The following is a description of a gene set: Human Gene Set: HP_ABNORMAL_MYELINATION Any anomaly in the process by which myelin sheaths are formed and maintained around neurons. species: Homo sapiens Abnormal myelination, and this is the list of marker genes: RNASEH1, NDUFS6, NDRG1, NRROS, NDUFS4, EIF2B1, MPZ, TYMP, BCS1L, GLUL, DHFR, GNAO1, HMBS, TAF2, LAMB1, PIGY, PGAP3, ALG9, ARHGEF10, ITPA, FANCB, PIGA, INTU, NAE1, ZFYVE26, NDUFS3, NR2F1, IDUA, CRELD1, ACTL6B, GRIN1, GRIN2D, KIF1B, TAF13, IER3IP1, LEMD2, PGAP1, GEMIN4, PIGS, COG3, GBF1, PRUNE1, SLC12A5, AP3B2, CHKA, FOXP1, MT-TH, CLTCL1, IREB2, VRK1, ESAM, SMPD4, SLC35B2, KARS1, MT-CO3, SHANK3, NDUFV2, GABBR2, IFIH1, SNIP1, PRF1, MT-ND6, TMEM126B, NGF, TIMM22, ZNF335, GDAP1, SLC2A1, TMEM147, KCNT1, SDHB, DYRK1A, GFAP, LIAS, TWNK, CYFIP2, TYROBP, NDUFS1, WWOX, COG7, SP110, MT-ATP6, ALS2, NIPBL, HS2ST1, BOLA3, MED17, POLR3B, POLR1C, FCSK, RMND1, IBA57, UBA5, GRM7, YARS1, BMP4, FOXG1, MME, DALRD3, NCDN, PTEN, TAOK1, TFG, MTTP, ARID1B, ATP6V1A, FIG4, GTF2H5, PEX10, COG5, DHX30, DARS1, CHAMP1, EXOC2, TPR, RAB3GAP2, TXN2, EPRS1, NDUFAF1, TRAK1, KCNB1, RAB7A, INTS11, LITAF, NDUFS7, BAG3, AIFM1, AHDC1, GNB1, PI4KA, MMACHC, CLCN3, CLDN11, NDUFV1, GAA, ARX, PPP2CA, CSF1R, PIGO, TRMT5, GRIN2A, KMT2E, TREM2, DDOST, MAT1A, UFC1, ATXN2, COA7, AHCY, MT-CO2, WDR26 (NCBI Gene Id 80232), YME1L1, ERCC2, INSR, PIGU, DHH, NUP188, COA8, FUS, PNPT1, ADAR, FLVCR1, ARF1, PRPS1, TIMMDC1, NDUFB11, TGFB1, RNF168 (NCBI Gene Id 165918), TMEM63A, TRAPPC11, RFX7, CNTNAP1, MDH2, ZNHIT3, ALG14, ASPA, RNU7-1, MT-TL1, ZFR, PIGN, AFG3L2, KCNA1, PEX13 (NCBI Gene Id 5194), ATP11A, HYCC1, MT-TF, YY1, PPP1R15B, MT-ND1, DCAF8, CTNNB1, NDUFS2, ALDH6A1, ATP6AP2, KCNC2, DHX16, DMXL2, HNRNPU, MRPS22, CNOT3, POLR2A, TMEM240, SLC1A2 (solute carrier family 1 member 2), RETREG1, MANBA, SYNGAP1, POGZ, FOXRED1, HNRNPC, RNF113A, PRMT7, KCNJ10, ERCC4, CYB5A, ALG12, C2orf69, ELOVL1, PLCB1, MPLKIP, FBXL4, HEXB (hexosaminidase subunit beta), PSAT1, HARS1, EARS2, CTC1, POLR3A, PAK1, ATP9A, ADCY6, LIG3, ISCA2, MORC2, NUS1, ACY1 (NCBI Gene Id 95), RAB3GAP1, NDUFB10, TKFC, PPP3CA, DNM2, KCNH5, PEX7, D2HGDH, BCAS3, GPT2, SLC25A1, L2HGDH, EZH2, TUFM, RNASEH2B, FBP2, SAMHD1, GTPBP3, JPH1 (junctophilin 1), PGM3, GABRA2, VPS33A, CACNA1A, DARS2, FRMD5, SMG9, ALG8, PHACTR1, TMTC3, CTSK, PRX, STXBP1, PURA, CELF2, NUP133, BCAP31, MT-TS2, MLYCD, UBE3A, POLR1A, NDUFAF3, SZT2, SPTLC1, MT-TV, QARS1, C18orf32, SNORD118, NARS2, PIBF1, FGF12, OSTM1, MOCS1, LIPT2, RRM2B, UGDH, ALG11, SLC35A2, MARS1, PEX16, CLPB, CLTC, MPV17, RNF220, TNR, RARS1, RNU4-2, COX6B1, AIMP2, SLC1A4, KLC2, GJC2, SELENOI, CASK, SETD1A, GRIK2, SCN9A, FLRT1 (fibronectin leucine rich transmembrane protein 1), LSM11, SPTBN4, MTRFR, NTRK1, MT-TK, AP3D1, SMPD1, YWHAG, CTDP1, DDX6, ZFX, RAB11B, GATAD2B, NDUFB9, GNB2, PYCR2, SUMF1, EXOSC1, ARSA, ZNF526, PKDCC (protein kinase domain containing, cytoplasmic), SLC32A1, PIGQ, FLCN, C2CD3, NOTCH2NLC, POLG, LMX1B (LIM homeobox transcription factor 1 beta), ALG13, SLC13A5, NEFL, SPTAN1, ADAMTSL1 (NCBI Gene Id 92949), PGAP2, ERCC1, PLAAT3, UBTF, PIGP, DNM1, GCDH, MAPK8IP3, KIF5A, UPB1, TRIM8, GALC, PEX19, SLC30A10 (solute carrier family 30 member 10), ASNS, NDUFA6, ACER3, NGLY1, PRKDC, MTHFS, RAI1, HK1, FAR1, ERCC6 (ERCC excision repair 6, chromatin remodeling factor), EIF2AK2, SLC12A6, AARS1, MT-ND5, PMM2, HSPB8, ABCA1, SIN3A, SIK1, POU3F3, PLP1, EXOSC5 (exosome component 5), NDUFAF8, TBC1D24, NDUFA11, RNASEH2A, CUL3, SYNJ1, EGR2, INF2, ADSL, ERCC8, SCN8A, VPS13A, NTRK2, GET4, ELP1, IDH1, GFM1, RNASET2, DOHH, GJB1, GOLGA2 (golgin A2), SBF1 (NCBI Gene Id 6305), NDUFA1, SLC33A1, TIAM1, NEUROD2, GTF2E2, PHGDH, FDXR, DNMT1, NOP10, PTRH2, GABRG2, NDUFAF4, TRIM2, CYB5R3, YIF1B, RHOBTB2 (Rho related BTB domain containing 2), NDUFB3, TBCD, SLC6A1 (NCBI Gene Id 6529), CLCN7 (chloride voltage-gated channel 7), TUBB4A, GAN, PNKP, ALDH5A1, SPTBN1, TRNT1, KIF1C, PARS2, MT-ND4 (mitochondrially encoded NADH:ubiquinone oxidoreductase core subunit 4), NDUFAF5, ZMIZ1, HACE1, MCOLN1, PSAP, TREX1, ALDH7A1, CACNA1B, NRCAM, TRAPPC2L, ISCA1, ZC4H2, PLAA, MT-TW, FRMPD4, PDYN, SIGMAR1, NEDD4L, HCFC1, SCO2, SOX10, STAMBP, PACS2, GABRA5, HSPD1, KCNN2, ERCC3, FBXO28, WARS1, HIKESHI, COX14, PIGL, HCN1, COX6A1, MT-TQ, FUCA1, ABCD1, ABAT, SCN2A (sodium voltage-gated channel alpha subunit 2), WNK1, CACNA1I, SLC25A12, DAG1, SATB2, ABHD12, EXOC8, SCN3A, SHPK, MAN2B1, PIGW, TMEM163, SLC16A2, TRRAP, MTMR2 (NCBI Gene Id 8898), MFN2, MRPL39 (mitochondrial ribosomal protein L39), COPB2, CLP1, CNKSR2, CDK19, CDC40, SURF1, DPM1, TDP1, PIGV, DNAJC3, NMNAT1, HSD17B4, ADAT3, ADARB1, NDUFS8, PDGFRB, PLEKHG2, PPFIBP1, EXOSC2, GMNN, EDNRB, NARS1, GLRX5, ALG2, SYT1, RBM8A, MMUT, DPAGT1, NUBPL, ACBD5, SLC25A22, IFT56, SCN1B, RNF13, TARS1, PMP2, FOCAD (focadhesin), MED27, HTRA1, CDKL5, NDUFAF2, ZNF148, HLA-DQB1, REPS1, CACNA2D1, MT-CO1, DEGS1, TNPO2, PPP2R1A, ELOVL4, RAP1GDS1, EEF1A2 (NCBI Gene Id 6669), AFG2A, BRAT1, KIDINS220, SBF2, ASXL1, NKX6-2, U2AF2, MT-ND2, SLC6A8, GLS, CLCN4, MTRR, PMP22, CARS1, H4C5, FGD4, FZR1, RERE, SLC19A1, NFU1, SOX3, PC, DHDDS, TBCE, ACOX1, RFC1, WARS2, ATP1A2, TEFM, MOCS2, COX7B, PIGG, SLC38A3, LMNA (lamin A/C), TRMT10A, PLPBP, FANCL, MOGS, TMEM106B, DNM1L, YRDC, SH3TC2, PLEKHG5, DCX, RNASEH2C, CYP27A1, SPG11, PPIL1, GLYCTK, ATP1A3, ATP7B, NECAP1, APTX, SACS, ZNF699, ASH1L, ALDH3A2, ACO2, OCA2, VPS11, ADGRG1, ARNT2, SEPSECS, EP300, GNB4 (G protein subunit beta 4), MADD, DHX37, KDM1A, KCNA2, CREBBP, KCNQ2, GABRB2 (NCBI Gene Id 2561), ERCC5, FA2H, AIMP1, KIF1A, NADK2, PEX1, LRPPRC, MT-ND3, HLA-DRB1, LIPT1, COQ7, NACC1, SCN1A (NCBI Gene Id 6323)